Given this list of marker genes EIF1B, NME1, EIF1, G3BP1, EIF4B, DHX29, PTCD3, LARP1, UNG, MTIF2 (NCBI Gene Id 4528), NPM1, EIF4H, MCTS1, ABCE1, ERAL1, PIM1, DDX3X, USP16, MTIF3, CPEB2, here is a description of the gene set: Human Gene Set: GOMF_RIBOSOMAL_SMALL_SUBUNIT_BINDING studied in species Homo sapiens Binding to a small ribosomal subunit.